Given this list of marker genes NOLC1, POLR2A, KANSL2, UBE2C, TRAF4, TGFBI, GRK5, NECAP1, FAM53A, SSR2, F5, NRAS, COIL, COASY, MEF2A, TCEAL9, HIF1A, DYNLT1, EIF4ENIF1, MTF2 (NCBI Gene Id 22823), PAPOLA, VAV1, ATF4, EMP3, BIRC3, B3GNT2, BMP10, SLC30A1, ZBTB20, PAK2, MINPP1, MKLN1, LCN2, EMB, PABPN1, ACR, ACOD1, GGPS1, JUN, PGD (NCBI Gene Id 5226), BMP8B, GAPDH, HRC, PRKCB, DDR1, TARDBP, SDC2, LYL1, OTC, FSTL3, HOXB9, RRM2, ST6GALNAC5, NPHP1, SIAH1, TACR1, CD160, SAA1, MIPOL1, PARP16, NELFA, GNS, ACP6, TRPC5, BOLA3, PCLAF, USP9X, RIC8A, UGP2, ANXA10, ASXL1, KLF17, STAM2, LLGL1, GABARAPL1 (GABA type A receptor associated protein like 1), ZFP37, AXIN1, MAFF, TSSK2, RALB, SKI, HYAL2 (NCBI Gene Id 8692), CTSG, FKBP4, BCL3, SERPINB2, LTBP3, KLF9, LIG3, DOCK5, ECPAS, NME6, POU5F1, USO1, TRPC4AP, SOAT1, STAC, EIF3F, AP3S2, DPM2, GRIN2C, BLMH, FSTL1, AQP1, MAP1LC3B, MYOG, AREG (amphiregulin), PTRH2, SYPL1, GLO1, TXNRD1, SRXN1, HOMER3, MMP13, TEX264, SIDT2, ADGRB1, EIF2B1, ATP6V1E1, TMUB2, KHDC1L, CTSV, NCAPH, KYAT3, GPSM1, ALCAM, CDK1 (cyclin dependent kinase 1), WDR45, CPEB1, P2RX7, PRDX1, KCNN4, HNRNPU, HRH2, GAA, RHPN2, CAPN9, ABCC3, B3GALT1, CYBB, KAT7, ASF1A, NME3, FRRS1, PDPN, OR2H1, DLX2, POPDC3, ATP1A1, WARS1, CD93, ORC2, UBR4, PUM3 (pumilio RNA binding family member 3), ESD, C11orf16, CRYGB, PLAUR, HCN1, CXCR3, GFER, MCRIP1, CCR1 (NCBI Gene Id 1230), TXNDC5, SLC5A1, TMEM50B, RPA2, NR1H4, R3HCC1, GJC1 (NCBI Gene Id 10052), TMEM208, HOXC8, LIPA, GOLIM4, ATP13A2, RAB33B, SIM2, LAMP2, KIN, ARMC1, ESYT1, TDRP, HMX1, PTPRK, PIM1, PRDX4, NR5A1, XRCC5, TNFAIP2, CLEC4D, KIF4A, TEAD1 (NCBI Gene Id 8), CEBPB, SSR3, GP1BA (glycoprotein Ib platelet subunit alpha), KDR, ITGAM, CTSK, TIPARP, DPP7, here is a description of the gene set: from publication Toker A, Engelbert D, Garg G, Polansky JK, Floess S, Miyao T, Baron U, Düber S, Geffers R, Giehr P, Schallenberg S, Kretschmer K, Olek S, Walter J, Weiss S, Hori S, Hamann A, Huehn J (PMID 23420886) Human Gene Set: GSE42021_TCONV_PLN_VS_CD24LO_TCONV_THYMUS_DN We investigated at which stage of maturation commitment to a stable Foxp3-expressing phenotype takes place. We assessed stability of Foxp3 expression in thymic Foxp3+ Treg subsets of different maturity, defined by CD24 expression. Next we compared gene expression profiles of Foxp3+ Treg subsets (+) of different maturity (24lo, 24int, 24hi) and could identify a set of genes that were specifically up or downregulated in Foxp3+ Tregs, but not in Foxp3- conventional T cells, in a maturation-dependent manner. Genes down-regulated in T conv: peripheral lymph nodes versus thymic CD24 low. studied in species Homo sapiens